Given this list of marker genes RAB11B, RC3H2, SRP54, CORO1B, ARID1A, IFNGR2, TMIGD1, ARMCX6, CA2, DUSP28, SNRNP27, ARF3, AEN, RBM6, CHAC2, FCER1G, USP53, XYLT2, ITPR1, USPL1, AGTRAP, HERC1, SPECC1L, LAMA4, NHLRC2, LAD1, FAM114A1, TNS4, PIKFYVE, NCKAP1L, CRBN, TTI2, NETO1, RFX5, AKAP13, ADAMTS4, TTC39C, LCK, IFITM2, CREB3, ZDBF2, KATNA1, BCL2L2, KMT2C, NRBP1, DOCK10, TJAP1, ZSWIM8, CISH, TRIB1, DNAJC1, C20orf96, FLRT2, SLC39A2, EHBP1L1, ANKLE2, LEMD2, KCNA2, KIN, KDM5D, CABIN1, HABP2, NFE2L1, ARFGAP1, SEC23B, TMEM179B, DLGAP4 (DLG associated protein 4), DCN, TMEM68, APPBP2, AIM2, TRIM39, PSEN1, GSC2, GSKIP, MED11, ANXA6, SNX18, KIF12, LRIG2, PSMA3 (proteasome 20S subunit alpha 3), TSKS (NCBI Gene Id 60385), ZHX2, EGLN2, CIAPIN1, CHIA, EGFL8, MED10, MYO10, TMEM248, STK19, VIP, SLC30A6, THRAP3, RNASE10, TRIM36, TCF20, EXOC6B, TRPC4AP, RAB21, VOPP1, RAP1B, PPRC1, FICD, POLM, RNPEPL1, FOXRED1, PRDM2, WAC, CACNA1D, PLTP, NXPE3, GPR132, SLC49A4, ZC3H4, ACP5 (NCBI Gene Id 54), ADM, ZNF236, DENND1B, FOXJ2, PLSCR1, TXNDC9, RNF24, PIAS1, OLR1, SWT1, DSEL, H2AB2, UBXN4, MIF4GD, SPINK4, MYB, ZNF628, SPEN, CCNT1, UGT2B10, GCKR, MTMR11, CCL2, MT1E, ALPK1, SYVN1, ITPRIP, TRAM2, ZEB1, CRISPLD1, PSMD11, PPP4R1, ZNF436, ATXN7, PPFIA3, SLC30A9, IL2RA, ATP11A, SLC25A1, TXN, RILPL1, OAF, CAPZA2, ACBD3, SH3BP2, CSF2RB, CDS1, GNA13, EPS15L1, KMT2E, DHX38, SPHK2, DPEP3, TMEM219, EZR, BAIAP2L1, GPR27, DOT1L, PLAC8, TBC1D1, FRRS1L, MORF4L2, NBAS, CPSF7, HTR1B, MAPKAPK5, DEDD (death effector domain containing), LPAR4, ZEB2, COX11, DEFB119 (defensin beta 119), TMEM67, CHORDC1, MED21, SLC31A1, JMJD6, DSE, SENP7, AFG2A, PNPLA2, KPNA4, TSPAN3, GTF2A1, here is a description of the gene set: studied in species Homo sapiens from publication Litvak V, Ramsey SA, Rust AG, Zak DE, Kennedy KA, Lampano AE, Nykter M, Shmulevich I, Aderem A (PMID 19270711) Genes down-regulated in comparison of macrophage cells stimulated with LPS (TLR4 agonist) for 40 min versus macrophage cells stimulated with LPS (TLR4 agonist) for 360 min. The innate immune system is a two-edged sword; it is absolutely required for host defense against infection, but if left uncontrolled can trigger a plethora of inflammatory diseases. Here we used systems biology approaches to predict and validate a gene regulatory network involving a dynamic interplay between the transcription factors NF-κB, C/EBPδ, and ATF3 that controls inflammatory responses. We mathematically modeled transcriptional regulation of Il6 and Cebpd genes and experimentally validated the prediction that the combination of an initiator (NF-κB), an amplifier (C/EBPδ) and an attenuator (ATF3) forms a regulatory circuit that discriminates between transient and persistent Toll-like receptor 4-induced signals. Our results suggest a mechanism that enables the innate immune system to detect the duration of infection and to respond appropriately. Human Gene Set: GSE14769_40MIN_VS_360MIN_LPS_BMDM_DN